The following is a description of a gene set: Enables the transfer of guanine nucleotides (GMP, GDP, and GTP) from one side of a membrane to the other. species: Homo sapiens Human Gene Set: GOMF_GUANINE_NUCLEOTIDE_TRANSMEMBRANE_TRANSPORTER_ACTIVITY, and this is the list of marker genes: LRRC8A, SLC19A1 (NCBI Gene Id 6573), SLC17A9, SLC46A2, ABCC4